Given this list of marker genes STK38L, SPSB1, ZNF354A, SNORD89, DNMT3B, JPH3, LPAR1, FAM3C, ANKRD34B, CPD, TTLL4, SKIL, NPAS4, SNTG1, CD8A, RNF149 (NCBI Gene Id 284996), BATF2, APEH, KLRD1, TDRD1, NR4A3, LRRC66, HOXA10, SLC35B2, IRF8, SPMIP3, ZNF706, AKT3, RNASE6, IQCC, STRA8, ZDHHC8, SFTPC, MED10, IQCE, MTUS1, ABHD15, TNFSF8, CLK3, CLIC6, KBTBD7, KCTD11, NEK6, CABLES1, ISM1 (NCBI Gene Id 140862), F2RL1, CTSC, CAPG (capping actin protein, gelsolin like), PMEPA1, CHD1, GAL3ST4, PRKCZ, LITAF, TRMT10A, CES1, BCLAF3, LCA5L, RCAN3, DDI1, SCMH1, IGFLR1, ART1, ZDHHC23, AGFG1, LTK, AHR, CLNK, SNX17, IL17B, MMP11 (NCBI Gene Id 4320), FAM234B, SUSD3, ARMC7, COL4A1, FZD10, EFCAB6, PPP1R16B, EPHA8, TTC39B, UGT8, PTAFR, KIT, TRPC4AP, PRDX6, BRINP3, DEXI, DNAJC9, ZBTB18, TINF2, CD38, NSUN4, TRAPPC14 (NCBI Gene Id 55262), FHAD1, BCO1, ENDOU, MB21D2, PANK4, CD8B, MAP7D1 (MAP7 domain containing 1), CBX8, FGD1, CC2D1A, DENND4A, KANK1, SMPD5 (NCBI Gene Id 392275), KLRK1, ART4, RHOC, IL1B, GAPVD1, GRIA4 (glutamate ionotropic receptor AMPA type subunit 4), HNRNPLL, APCS, IRF3, CTSW, DNTTIP1, CIB1, MPZL2, ACP3 (NCBI Gene Id 55), ARID5A, GPR18, APLNR, LMX1B, RDH10, WEE1, DIAPH2, GPR68, LDLRAD4, GPR155, EGFR, TONSL, NCF1, GPRIN3, PDCD1, SPATA2L, PTPN11, SPOCK3, NMT2, RPA1, NFKBIE, SNAI3, KDM1A, CYGB, ZNF644, FOXM1, GABARAPL1, QPRT, TRIO, TAGAP, SLC15A1, DAPK2, RUNX2, RAB20, LPAR3, SELENOV, SLC39A4, RIN2, SMYD3, COMMD7, SMIM3, SNHG11, TMCC3, BCAS3, LHX8, HMGB4 (NCBI Gene Id 127540), AFF3, NT5E, JOSD2, NRARP, FAM78A, UNC5A, ANKRD50, LFNG, RASGRP2, THY1, IGF2-AS, LSM1, CEMIP2, ATP6V1D, SEPTIN12, NKD2, FHL3, LRRC2, GGN, GRM7, SLC22A1, CYP1B1, B3GNT8, NANP, NT5M, ITGAE, SERPINH1, CDH1, C1orf21, THAP1 (NCBI Gene Id 55145), RAI1, FES, TNFSF10, ADCY5, VPS25, here is a description of the gene set: Human Gene Set: GSE7460_CTRL_VS_TGFB_TREATED_ACT_FOXP3_MUT_TCONV_DN from publication Hill JA, Feuerer M, Tash K, Haxhinasto S, Perez J, Melamed R, Mathis D, Benoist C (PMID 18024188) The transcription factor Foxp3 is usually considered the master regulator for the CD4+CD25+ Genes down-regulated in comparsion of sfActCD4 versus sfActCD4TGF (see Fig. 1 in the paper for details). species: Homo sapiens